The following is a description of a gene set: Mouse Gene Set: GOBP_EMBRYONIC_APPENDAGE_MORPHOGENESIS species: Mus musculus The process, occurring in the embryo, by which the anatomical structures of the appendage are generated and organized. An appendage is an organ or part that is attached to the trunk of an organism, such as a limb or a branch., and this is the list of marker genes: Shox2, Traf3ip1, Cyp26b1 (NCBI Gene Id 232174), Pitx1, Tbx2, Intu, Tbc1d32, Bax, Notch1, Mks1, Hoxd10, Mbnl1, Hoxd9, Lrp4, Nipbl, Gja1, Wdpcp, Pitx2, Gnaq, Fbxw4, Pbx1, Wnt9a, Ctnnb1, Fgf4, Hand2, Ext1, Hoxd12, Ift52, Alx4, Hoxd11, Gnas, Lmx1b, B9d1, Ttbk2, Osr1, Fgfr1, Pbx2, Hoxd13, Cplane1, Wnt7a, Aldh1a2, Hdac2, C2cd3, Map3k20, Hoxa11, Ece1, Smarca4, Ift140, Runx2, Cacna1c, Grhl2, Chd7, Megf8, Fuz, Wnt5a, Twist1, Sall1 (NCBI Gene Id 58198), Mycn (v-myc avian myelocytomatosis viral related oncogene, neuroblastoma derived), Sp9, Trp63, Aff3, Lnpk, Gas1, Prickle1 (NCBI Gene Id 68784), Bmp4, Alx3, Fgf8, Tmem107, Rspo2, Dlx6, Wdr19, Lef1, Tbx5, Ror2, Nog, Shh, Alx1, Hdac1 (NCBI Gene Id 630524), Sall4, Fzd6, Hoxa9, Hoxc11, Notch2, Grem1, Dync2h1, Ski, Fras1, Tgfb2, Tfap2a, Ift122, Ift88, Bmpr1a, Dlx5, Bcl2l11, Msx2, Dkk1, En1, Rpgrip1l, Gna12, Frem2, Hoxc10, Tbx4, Reck, Tulp3, Bpnt2, Lmbr1, Mosmo, Acd, Rdh10, Gpc3, Sfrp2, Psen1, Hnf1a, Gdf5, Lrp5, Flvcr1, Smad4, Rab23, Mecom (MDS1 and EVI1 complex locus), Rarb, Hoxa13, Msx1, Gja5 (gap junction protein, alpha 5), Rarg, Tbx3, Ihh, Fbn2, Ptch1, Chst11, Tmem231, Prrx2 (paired related homeobox 2), Prrx1, Gli3, Zbtb16, Osr2, Sp8, Bmp7, Psen2, Wnt3, Gli2, Dicer1, Med1, Fgf9, Hoxa10, Crabp2, Lrp6